The following is a description of a gene set: Human Gene Set: WP_ETHER_LIPID_BIOSYNTHESIS Ether lipid biosynthesis species: Homo sapiens, and this is the list of marker genes: PEDS1, GAL3ST1, LPIN2, FAR2, GNPAT, UGT8, PEX1, PEX7, PEX5L, LPCAT1, FAR1, AGPS, ARSA, PEX3, LPIN3, CEPT1, PEX16, PEX19, DHRS7B, LPIN1